The following is a description of a gene set: Fulminant hepatic failure Human Gene Set: HP_FULMINANT_HEPATIC_FAILURE species: Homo sapiens Hepatic failure refers to the inability of the liver to perform its normal synthetic and metabolic functions, which can result in coagulopathy and alteration in the mental status of a previously healthy individual. Hepatic failure is defined as fulminant if there is onset of encephalopathy within 4 weeks of the onset of symptoms in a patient with a previously healthy liver., and this is the list of marker genes: HADH (hydroxyacyl-CoA dehydrogenase), GFM1, KRT18, POLG2, XIAP, IL18BP, SH2D1A